The following is a description of a gene set: A G protein-coupled receptor signaling pathway initiated by somatostatin binding to the somatostatin receptor (SSTR) on the surface of a target cell, and ending with the regulation of a downstream cellular process. Mouse Gene Set: GOBP_SOMATOSTATIN_RECEPTOR_SIGNALING_PATHWAY species: Mus musculus, and this is the list of marker genes: Sstr1, Sstr2, Sstr3, Sst, Sstr5, Sstr4, Cacna1a